The following is a description of a gene set: studied in species Homo sapiens The series of molecular signals in which an intracellular signal is conveyed to trigger the apoptotic death of a cell. The pathway is induced in response to a stimulus indicating endoplasmic reticulum (ER) stress, and ends when the execution phase of apoptosis is triggered. ER stress usually results from the accumulation of unfolded or misfolded proteins in the ER lumen. Human Gene Set: GOBP_INTRINSIC_APOPTOTIC_SIGNALING_PATHWAY_IN_RESPONSE_TO_ENDOPLASMIC_RETICULUM_STRESS, and this is the list of marker genes: DDIT3 (NCBI Gene Id 92982), BAX, PMAIP1, CREB3L1, ERN1, AIFM1, TMEM238L, CHAC1, HYOU1, BRSK2, NCK2, CREB3, XBP1 (NCBI Gene Id 7494), BCL2L1, MAP3K5, BCL2, TMBIM6, PRKN, WFS1, RNF183, ATP2A3, APP, LRRK2, ERO1A, GRINA, SELENOS, SYVN1, OPA1, CASP4, MAGEA3, NCK1, TRIB3, BOK, ATF4, HERPUD1, BBC3, BAG6, ITPR1, EIF2AK3, HSPA1A, PDX1, TXNDC12, SERINC3, DNAJC10, SIRT1, TRAF2, ATP2A1, TNFRSF10B, BAK1, APAF1, PTPN2, ERP29, PPP1R15A (NCBI Gene Id 23645), PARK7, ERN2, FCGR2B, PML, RNF186, QRICH1, SELENOK, BCL2L11, TMEM117, IKBKG, TP53, CEBPB, DAB2IP, PTPN1